Given this list of marker genes RAB8A, EMILIN2, CBL, CD200R1, NCF4, FSTL1, MFSD1, TNN, ADAR, SLC15A3, PRDX1, HTRA1, SRD5A3, CD37, NDC1, STX11, TGFB1I1, GABARAP, TMEM68, AP3B1, IL17RA, LIMA1, KMT5C, PKP3, GNPTAB, SNX18, PPP1R18, NCF1, MMP2, ERI1, HCK, SH3TC1, PEDS1, LIX1L, ANLN, SLC43A2, CREB3L1, CYBB, SHTN1, TRAM2, ADAMTS7, ZNF469, MANF, PGD, HPSE, CDK6, AP1B1, NIPSNAP3A, ICOS, CNPY3, BTK, VWA5A, CMTM7, HLA-DMB, ERMARD, ASAH1, PDIA3, PLOD3, SNX1, SLC38A10, DTX4, IL27RA, GLIPR1 (GLI pathogenesis related 1), CCR1, SKIL, TYROBP, DOK3, SLC30A5, SETDB1, XDH, EDEM1, PDCL, TMED9, RGS10, PISD, ZC3H7A, METRNL, LITAF, SAMHD1, NLN, MARCO, TPP1, SIAE, HIF1A (NCBI Gene Id 3091), TRPV2, INPP5D, TMEM123, ANXA1, CCL5, SLC25A45, FRRS1, DNM2, HVCN1, PILRA, GSDMD, C1QA, WAS, ANXA2, CYSLTR1, SORCS2, NECTIN1, ASXL2, KCNN4, GDA, PIK3CG, SEMA4D, PTGER2 (NCBI Gene Id 63381), MYO7A, COL16A1, CD40, RBM47, PTGS2, GALNT7 (polypeptide N-acetylgalactosaminyltransferase 7), SH3BGRL3, DAP, FAM167A, MTCL2, M6PR (mannose-6-phosphate receptor, cation dependent), LOXL1, LAMP1, SEC24D, MFSD10, PTGFRN, TMX3, TES, RNF128, SLC16A2, TNFRSF11A (TNF receptor superfamily member 11a), SRI, LRP8, MED7, MSC, FBRS, TRPS1, PTGR1, GPX1, UNC93B1, TMEM51, SLAMF8 (NCBI Gene Id 56833), CSTB, ITGA5, CASP8, PPP4R1, C18orf54, MEFV, NFKBIE, FES, TCIRG1, ARAP1, ELK3, CD80, RAB8B, CMIP, NCKAP1L, PLA2G7, CSF2RB, MPP1, PDLIM4, CFP, TNFAIP3, SDCBP, TM4SF5, CCR2 (NCBI Gene Id 90262), ZFP36L2, ABCA1, ASS1, MGAT1, CLEC4A, SLC37A2, LCP2, HEPACAM2, CD48, CSK, ITGAX, AP1S1, TGIF1, DCSTAMP, IGSF6, NIBAN2, STAC2, LGALS3BP, PNP, SELPLG, SF3B3, JPT1, CYP7B1, CASP6, CKLF (NCBI Gene Id 51192), ESPL1, MOB1A, FCER1G, NCF2, EFHD2, PTK2B, LPCAT2, LHFPL2, SHISA5, SULF1, CERS6, IFI30, here is a description of the gene set: from publication Qualls JE, Neale G, Smith AM, Koo MS, DeFreitas AA, Zhang H, Kaplan G, Watowich SS, Murray PJ (PMID 20716764) species: Homo sapiens Nitric oxide (NO) produced by macrophages (MØs) is toxic to both host tissues and invading pathogens and its regulation is therefore essential to suppress host cytotoxicity. MØ arginase 1 (Arg1) inhibits NO production by competing with NO synthases for arginine, the common substrate of NO synthases and arginases. Two signal transduction pathways control Arg1 expression in MØs. First, a MyD88-dependent pathway induces Arg1 in intracellular infections, while a second Stat6-dependent pathway is required for Arg1 expression in alternativelyactivated MØs. We found that mycobacteria-infected MØs produce soluble factors that induce Arg1 in an autocrine-paracrine manner via Stat3. We identify these factors as IL-6, IL-10 and GCSF. We further establish that Arg1 expression is controlled by the MyD88-dependent production of IL-6, IL-10 and G-CSF rather than cell intrinsic MyD88 signaling to Arg1. Our data reveal the MyD88-dependent pathway of Arg1induction following BCG infection requires Stat3 activation and may result in the development of an immunosuppressive niche in granulomas due to the induced Arg1 production in surrounding uninfected MØs Genes up-regulated in macrophages: wildtype versus MYD88 knockout. Human Gene Set: GSE22935_WT_VS_MYD88_KO_MACROPHAGE_UP